Given this list of marker genes CPSF6, CSTF3, PAPOLA, NUDT21, CPSF7, CPSF3, CPSF1, TUT1, SSU72, ZCCHC8, PCF11, here is a description of the gene set: Human Gene Set: GOBP_CO_TRANSCRIPTIONAL_RNA_3_END_PROCESSING_CLEAVAGE_AND_POLYADENYLATION_PATHWAY Any process involved in transcription termination-coupled 3' processing of RNA polymerase II RNA transcripts by 3' end cleavage and addition of a poly(A) tail. species: Homo sapiens